The following is a description of a gene set: from publication Gao S, Yan L, Wang R, Li J, Yong J, Zhou X, Wei Y, Wu X, Wang X, Fan X, Yan J, Zhi X, Gao Y, Guo H, Jin X, Wang W, Mao Y, Wang F, Wen L, Fu W, Ge H, Qiao J, Tang F (PMID 29802404) Human Gene Set: GAO_LARGE_INTESTINE_24W_C5_LGR5POS_STEM_CELL species: Homo sapiens, and this is the list of marker genes: RNF186, CHMP4C, LIPG, RNF157, CPA6, ARSL, SLPI, LGR5, CLDN15, LEFTY1, PKP2 (NCBI Gene Id 93271), SULT1B1, ACVR1C, PLAGL2, PLEKHH1, ZNF296, ATP10B, SCAND3, C16orf89, HNF1A, LY6G6D, PPP1R1B, NOX1, SLC38A4 (solute carrier family 38 member 4), CLDN2, MGST1, DDC, GDF15, NHERF4 (NHERF family PDZ scaffold protein 4), CDCA7, TMEM171, ITPKC, SOX9, MYOM3, RGMB, GATA6-AS1, TSPAN8, GJB1, PTGDR, PCSK9, KMT2E-AS1, EFNA3, GJB2, ADH1C, OLFM4, EVPL, CFTR, HSD17B2, TAF4B, F2RL1, DAPK2, SLC27A2 (solute carrier family 27 member 2), GOLT1A, CHP2, ACAD10, GPX2, C6orf136, FOXD2-AS1, SFN, URB1-AS1